The following is a description of a gene set: Human Gene Set: GSE43955_TH0_VS_TGFB_IL6_TH17_ACT_CD4_TCELL_42H_DN species: Homo sapiens from publication Yosef N, Shalek AK, Gaublomme JT, Jin H, Lee Y, Awasthi A, Wu C, Karwacz K, Xiao S, Jorgolli M, Gennert D, Satija R, Shakya A, Lu DY, Trombetta JJ, Pillai MR, Ratcliffe PJ, Coleman ML, Bix M, Tantin D, Park H, Kuchroo VK, Regev A (PMID 23467089) Despite their enormous importance, the molecular circuits that control the differentiation of Th17 cells remain largely unknown. Recent studies have reconstructed regulatory networks in mammalian cells, but have focused on short-term responses and relied on perturbation approaches that cannot be applied to primary T cells. Here, we develop a systematic strategy – combining transcriptional profiling at high temporal resolution, novel computational algorithms, and innovative nanowire-based tools for performing gene perturbations in primary T cells – to derive and experimentally validate a temporal model of the dynamic regulatory network that controls Th17 differentiation. The network is arranged into two self-reinforcing and mutually antagonistic modules that either suppress or promote Th17 differentiation. The two modules contain 12 novel regulators with no previous implication in Th17 differentiation, which may be essential to maintain the appropriate balance of Th17 and other CD4+ T cell subsets. Overall, our study identifies and validates 39 regulatory factors that are embedded within a comprehensive temporal network and identifies novel drug targets and organizational principles for the differentiation of Th17 cells. Genes down-regulated in CD4 T helper cells (42h): Th0 versus TGFB1 and IL6., and this is the list of marker genes: TMEM222, SPIC (Spi-C transcription factor), NFATC2, CSF2RB, BEX4, SMYD1, EFNB3, IER2, CLCNKB, TMEM41B, ITGAE (NCBI Gene Id 3682), ZNF274, SEPTIN4, MYH4, BMP4, S100A8, USP38, LRG1, EZR, CALML4, HPX, PCBD1, NGEF, SSX2IP, RAB3B, PTPN6, BTN1A1, CXCL13, SIM1, ZNF600, NUMB, H3-5, PCSK6, CFB, WNT10A, CLPX, IDE, DNM1, INPP5K, NYNRIN, CA1, BATF, MAL, GHRL, CA2, CSF3R, ACAD9, PFKL, NTF3, WDR45B, PIAS2, NSMCE1, MMP12, CPXM1, SELP, PRKG2, BCKDHA, UNC5C, HP, ATG12, AUH, RSU1, CLEC4F, IL4R, ABCF3, RECQL, ORC5, THBS3, CHCHD5, ATP4B, MTX1, ZBTB16, IL1RN, RYR2, PEG3, PLK2, MCUR1, HSPB2 (heat shock protein family B (small) member 2), NAV1, DDT, GBF1, UPP2, PHKG1, MESP1, C6orf89, JMJD6, ST3GAL4, TBL1XR1, TNNT2, MARCKS, FBXO21, GGT5, TCF4 (transcription factor 4), INPP4A, PAQR7, ZFAND5, ARG2, C4BPA, VAX1, MICOS13, SLC1A2, KDM3A (NCBI Gene Id 55818), NAB2, NCOR1, DAB2, LGALS2, RIMKLB, RUNX1T1, INPP5B, NXT1, DNAJB8, RHOU, GPX5, RALGDS, RAP1A, CAT, SCAMP1, ASPSCR1, VAC14, RNF123, NDRG4, CDKN2AIPNL, PNN (NCBI Gene Id 5411), GAB1, SELENOT, PROCR, SOS2, GLIPR2, ATP6V0A1, TNFRSF11B, OR2H2, PRPF19, NEK6, ANK3, CD320, MTRF1L, LDHA, ALDH1A1, NKAIN1, CXCL9, BZW2, ELF5, HAL, ZXDB, POU2F3 (NCBI Gene Id 25833), ARHGAP45, CSN2, ID3, GRIN2D, SAA2, FABP5, TRIM47, DCP1A, PAX2, PRSS12, GFUS, UGCG, PDE6B, DYNC1I1, WNT3, TM4SF1, NAMPT, TRPC4, SHMT2, MTM1, CAVIN2, MEPCE, MAB21L2, DCAF12, IFRD2 (interferon related developmental regulator 2), TNIP1, MCOLN2, SLC66A2, NNAT, TAT, SEMA3C, TPI1, MRPL52, TUBA4A, ADAM28, SLTM, TMEM268, BPNT1, OPRK1, GLI2, TH, MST1, KRT77, STMN4, ACADS, TMPRSS15, AOX1, GIMAP4, BPHL, FCER1A, NRBP1, LCK, FOXD2, SLC38A4, RIOK3